Given this list of marker genes Scp2, Washc1, Adipoq, Lamtor1 (late endosomal/lysosomal adaptor, MAPK and MTOR activator 1), Apoc3, Lrp1, Apoa2, Commd1, here is a description of the gene set: Mouse Gene Set: GOBP_REGULATION_OF_CHOLESTEROL_IMPORT studied in species Mus musculus Any process that modulates the rate, frequency or extent of cholesterol import. Cholesterol import is the directed movement of cholesterol into a cell or organelle.